The following is a description of a gene set: Mouse Gene Set: GOBP_NEGATIVE_T_CELL_SELECTION species: Mus musculus The process of elimination of immature T cells which react strongly with self-antigens., and this is the list of marker genes: Cd74, Ptprc, Spn, Mink1, Cd28, Atg5, Aire, Cd3e, Ccr7, Themis, Fas, Shh, Dock2 (dedicator of cyto-kinesis 2), Gli3, Zap70